The following is a description of a gene set: studied in species Mus musculus Antigen Presentation: Folding, assembly and peptide loading of class I MHC Mouse Gene Set: REACTOME_ANTIGEN_PRESENTATION_FOLDING_ASSEMBLY_AND_PEPTIDE_LOADING_OF_CLASS_I_MHC, and this is the list of marker genes: H2-T23 (histocompatibility 2, T region locus 23), H2-M5, H2-Q7, Tapbp, Bcap31, H2-T22, H2-M10.2, Sec24a, Sar1b, Sec24c, Hspa5, H2-M10.6, H2-Q6, Canx (calnexin), H2-M11, Sec24b, H2-M9, Tap1, H2-M3, H2-Q4, H2-M1, H2-Q1, H2-M10.4, Tap2, Pdia3, H2-K1, Sec23a, H2-Q10, H2-T10, B2m, Calr, Sec31a, H2-M10.3, Sec24d, Sec13, H2-M10.1, H2-M10.5, Erap1, H2-M2, H2-Q2